The following is a description of a gene set: Human Gene Set: MIR593_3P Genes predicted to be targets of miRBase v22 microRNA hsa-miR-593-3p in miRDB v6.0 with MirTarget v4 prediction scores > 80 (high confidence targets). from publication Chen Y, Wang X (PMID 31504780) species: Homo sapiens, and this is the list of marker genes: SEZ6L, BPNT2, SP1, PACS2, DMRT3, RNF8, CD3G, CAMTA1, FOXO3, MEX3C, DTNA, MAP7D3, NUBP1, MAP3K9, MAP3K20, GRIK3, KLHL7, RIC1, POMGNT1, RSPRY1, MAN2A2, TIMM17A, PRR23E, CHFR, FABP7, ZNF236, FUT8, SLC35D3, CDKN1B, RORC, JAKMIP2, EEF2K, ZNF124, GATA2, CPLX2, ST6GALNAC3, CALU, PCSK5, HYAL1, ZNF608, CDY1, SIM2, CDKN2AIP, KIDINS220, FFAR3, CNIH3, CASP7, VASN, CDY1B, TRIM3, ILDR2, BHLHE22, CDK16, ERP27, ZNF112, YBX2, MOCS1, STAC2, PREX1, GPR89A, KDM5C, SHISA7, CYP8B1, DELEC1, ARCN1, GNL1, FGF11, TXNIP, CASK, IGSF3, CD101, ASXL2, SNAI2, ADCYAP1R1, BAP1, SLFN5, BIN2, LINC03106, PLEKHS1, FOSL1, SLC25A12 (solute carrier family 25 member 12), FOXC1, FRS2, NHLH2, MCC, SLC38A1, ZFX, KCNC4, ITIH6, SUSD6, ZNF879, TMEM64, TMEM231, TRAF3IP2, DHRSX, GATA5, RBFOX2, CCDC152, STXBP5L (NCBI Gene Id 9515), DLG2, CCL28, PSMB2 (NCBI Gene Id 5690), CCM2, LSM8, DSCAML1, KIAA0232, BAMBI, RNF170, POGK, MAMSTR, IL13, INAFM2, IDO1, SUCLG1, RRS1, BCL9, KIAA1217, AKIRIN1, ASH1L, NIF3L1, NTM, BMPR2, CYP2W1, ELOF1, RRP12, SZT2, SHC4, ZBTB10, KCNIP1 (NCBI Gene Id 442143), RFT1, FNDC1, EGR3, ZMYND19, TCF12, PRDM16 (NCBI Gene Id 647868), LMO4, LRP8, NTRK2, HABP2, TFCP2L1, GIGYF2, ABO, RGS13